The following is a description of a gene set: species: Homo sapiens A process by which viral mRNA is translated into viral protein, using the host cellular machinery. Human Gene Set: GOBP_VIRAL_TRANSLATION, and this is the list of marker genes: OAZ1, OAZ3, EIF3A, OAZ2, EIF2D (NCBI Gene Id 1939), MCTS1, FURIN, EIF3F, SSB, IFIT1, EIF3G, PCBP2, EIF3D, ATG5, TMPRSS2, EIF2AK4, DENR, ACE2, ATG12, SHFL, PEG10, EIF3B, PTBP1, ATP7B, EIF3L, CSDE1